The following is a description of a gene set: Human Gene Set: MATSUDA_NATURAL_KILLER_DIFFERENTIATION Valpha14i natural killer T (NKT)-cell function has been implicated in a number of disease conditions. The molecular events that drive Valpha14i NKT-cell development remain elusive. We recently showed that T-bet is required for the terminal maturation of these cells. Here we identify some of the genetic targets of T-bet during Valpha14i NKT-cell lineage development. Microarray gene-expression analyses on developing Valpha14i NKT cells were performed and provide a molecular framework to study these maturation events. In vitro ectopic expression of T-bet in immature Valpha14i NKT cells, which do not yet express T-bet, was sufficient to promote Valpha14i NKT-cell maturation, driving the expression of multiple genes, including those that participate in migration, survival, and effector functions. By regulating the expression of T-helper 1 (Th1)-associated cytokines, chemokines, chemokine receptors, and molecules involved in cytolysis, T-bet defines the unique lineage attributes of mature Valpha14i NKT cells and acts to link these attributes to a developmental process. studied in species Mus musculus from publication Matsuda JL, Zhang Q, Ndonye R, Richardson SK, Howell AR, Gapin L (PMID 16357323) Genes changed between developmental stages of Valpha14i natural killer T lymphocyte cells (NKT)., and this is the list of marker genes: SYT6, RPS6KA2, ST13, SOCS2, IL13, EPB41L3, GJD2-DT, SLC40A1, SPEG, B3GNT5, SV2A (synaptic vesicle glycoprotein 2A), TCF4, F2RL1, KIF1B, APCDD1, DHRS4, LRRK1, LITAF, CTNNBL1, GRWD1, PKM, SPRR1A, BCL11B, ZNF189, CD244, SMPD4, PPIH, HIP1, TACC2, ENG, COX5B, GTF2A1, SMPD2, HNRNPAB, FRMD4B (NCBI Gene Id 23150), CD302, POLR1E, CXCL2, TUBB2B, TBX21, RRM2, SHMT2, DDX3Y, ABCE1, RUNX2, ZNF207, CDK4, PFDN6, CD247, B4GALNT1, KIF22, KLF18, FOS, CDH1 (NCBI Gene Id 999), CALML4, TK1, PHF21A, KLF4, SH3D19, SCD, CTSD, ALDOA, ARHGAP24, PROZ, SLC28A2, SOX4, KLRB1, C17orf49, SORL1, ID3 (inhibitor of DNA binding 3), CXCL10, PRF1, RCBTB2, CD38, TCF7L1, SOX13, DOCK7, MCOLN2, SMO, ASPN, MEG8, CD160, ABCB1, CXADR, KLKB1, MAP4K5, CYB5B, NAPSA, IGKC, ZC3H12C, TKT, MTHFD1, ITSN1, CHAF1B, OTUD5, GPATCH4, TARS1, GPI, PHGDH, ZBTB16, CRIM1, PRRX1, MRPL12, IL1B, GCA, WWC2, FZD6, FBXL3, GFM1, GNB2, DDX49, TPI1, LYST, EBNA1BP2, PTPRF, CLCA3P, CA8 (carbonic anhydrase 8, NCBI Gene Id 767), TEX9, DTL, NEDD9, MRPL54, ITGB1, TM6SF1, FGL2, SLC22A25, GAS1, NISCH, ATAD3A, IFITM1, MMP13, EVI5 (ecotropic viral integration site 5), MCM2, MYCN, STAT5B, MAP2K7, MARCKSL1, DSG2, PPP4C, POSTN, SUV39H2, PTPRD, HSPA1B, NCAPG, EDF1, CISD1, PLBD2, TJP1, UBE3A, TNNT1 (troponin T1, slow skeletal type), TNPO2, ICA1, MS4A6A, TNPO3, SLC15A1, PLA2G2D, EIF5A, AHNAK, SYNCRIP, TF, FMN2, SYT7, EFEMP1, FASLG, TEX21P, SGK1, KCNJ8, PDLIM4, JCHAIN, SERPINB1, CSN3, IL2RB, ACTB, MERTK, RIBC2, PTPN22, SEC61A2, MTCH1, CCL4, ST3GAL6, KLRD1, DHRS3, ENDOD1, WIPF1, PPARGC1A, GGT5, GPR34, RNF19B, RFLNB, MPEG1 (NCBI Gene Id 219972), TULP3, EXOSC10, HSP90AA1 (NCBI Gene Id 89272), PPP3CC, SESN1, TFRC, VCP, CUBN, FSTL1, RELL1, NHP2, RHOC, TENT5C, MYO1E, CCR5, CHST7, PKP2, ZNF23, CD7, COL19A1, PLAGL1, PRSS23, SYTL2, RDH16, NCL, SLC35F5, TACC3, TLR3, CHCHD6, IFNGR1, ZNF136, KLRK1, PTPRJ, EPS8, ASNS, SPON1, ENC1, CCDC117, SFRP2, CCR9, ART2BP (ADP-ribosyltransferase 2B, pseudogene), KCTD12, CXCR3, CACNA2D3, PRXL2A, HEY1, RBM6, SAT1, GALK1 (galactokinase 1), PRMT1, NKG7, EBF1, KCNN4, SOX6, TEDDM3P, RNF25, ELOVL4, FLNA, VEGFD, ALS2, PDK3, MAPK10, CSRP1, SPON2, CYP24A1, PSMC4, GZMB, CDCA5 (cell division cycle associated 5), DAGLB, CDC23, BNC1, DAPK2, GPAT4, CXCR6, STXBP4, SCAMP1, FBLIM1, IGHG1, TP63, PFKL, TGFA, HOMER2, NDUFB10, GABRA1, RIPOR2, RAD54L, PRXL2B, MCM3, NR1D2, CLNK, HABP2, IGFBP4, CCL5, RPS18 (NCBI Gene Id 6222), HEXA, DST, MMAA, HOXA13, STMN1, TLE1, RHOT2, DTYMK, ZC3H7A, LATS2, ZFP91, SSRP1, TESC, LYZ, HOPX, CCR1, FEN1, FKBP4, MISP, TMEM30A (transmembrane protein 30A), ZBTB21, SLC6A15, SLC25A53, CORO1A, ATP6AP2 (NCBI Gene Id 95880), GRAP2, CCR7, PRIM2, RRP12, PSMD13, SIAE, SIM2, MYO5A, MDFIC, TCF7, SLC25A13, NUCB2, DSP, CEACAM21, ATP5MC1, LIMD2, SLC6A3, SGMS1, MAN1A1, DNAH8, IGF1, SLC5A4, CADM1, CAMK4, BUB1B, DENND5A, CSN1S2AP, UPF1, MRPL38, MYADM, PLSCR1, CFHR4, GALNT4, IFITM10, GALNT3, WDFY1 (NCBI Gene Id 57590), EDIL3, AIP, GEM, VDR, ABCB9, PVR, CD44, NCAPD2, SLC13A3 (NCBI Gene Id 64849), KIF11, POLR1D, TRGV11, SDAD1, CHD4, SYCE2, NTRK3, LY75, CARD10, SP4, SGO1, ENPP2, TIRAP, RIPK3, TASP1, SOCS3, PFN2, IFITM2, TMEM242, ID4 (inhibitor of DNA binding 4), SH3BGRL2, AKAP9, STAM2, TAB1, PAK1, FHIP1B (NCBI Gene Id 84067), ATMIN, ACLY, HLA-B, EPHA7, LZTFL1, OR5B3, STAB2, IPO4, PGAP4, IGHA2, PRMT3, RANBP1, SERPINA3, COL11A1, H19, OPRM1, TSC22D3, IFT46, RUVBL1, SARS1, AARSD1, PLAUR, UFD1, PLIN2, BICD1, TIMM13, TTC39B, H1-4 (NCBI Gene Id 3008), PPIL2, ENPP3, BUD31, PDCD1, OAF, CPEB1, CHST14, TMC1, ARMC6, WWTR1, SNORD1A, RGS1, PMEPA1, MCM7, EPHA3, MEF2C, IFNG, CPD, PPP3R1, AP3S2, TSPAN31, ACSF3, MAGI1, EBF2, TIMELESS, SLC16A2, SGCB, NAT8, FNBP4, FHL1, MRPL19, FKBP9, CCT7, LY86, SKA1, WDR54, SLAMF7, PDE7A, AHR, MCM5, MYO1F, SCUBE2, OASL2P (NCBI Gene Id 111216278), BRD3, ARL6, NRGN, LGI1, PINX1, NOP2, RPS14 (ribosomal protein S14), HSD11B1, SLC41A2, TYMS, MPP4, KLRC1, IRGM, STAT4, XCL1, POLG, CD36, ATP13A2, PPP2R5C, GRAMD2B, CBARP, XIAP, MATK, ANXA1, RECK, BHLHE40, HRH1, JUN, F2R, DPH5, LDHB, KLF6, CIITA, YES1, FKBP1A, PTGS2, TWF1, CACNB4 (NCBI Gene Id 785)